The following is a description of a gene set: studied in species Mus musculus Mouse Gene Set: GOCC_IGM_IMMUNOGLOBULIN_COMPLEX A protein complex composed of two identical immunoglobulin heavy chains of the IgM isotype and two identical immunoglobulin light chains, held together by disulfide bonds, and in its circulating form complexed with J chain in polymeric forms. An IgM immunoglobulin complex may be embedded in the plasma membrane or present in the extracellular space, in mucosal areas or other tissues, or circulating in the blood or lymph., and this is the list of marker genes: Igkv3-5, Igkv3-4, Igkv3-7, Igkv3-12, Igkv3-10, Igkv3-3, Igkv3-9, Igkv3-2, Ighm, Igkv3-1, Jchain, Cd79a, Igkv18-36, Cd79b